Given this list of marker genes TNF, CREB1, DGKQ, GFI1, LMF1, STAR, LDLR, PAQR3, APOA1, ABCA2, GNB3 (NCBI Gene Id 2784), KIT, MIR27A, SNAI1, ERLIN2, H6PD, ERLIN1, FGFR4, ASAH1, NR1H4, ARV1, DKKL1, INSIG1, STAT5B, STUB1, TSPO, ARMC5, ABCB11, RORC, MIR33A, PANK2, MIR98, ATP1A1, SEC14L2, MIR96, GNAI1, TTC39B, KPNB1, MALRD1, AQP8 (NCBI Gene Id 343), ADM, BMP5, UGT1A1, ABCG1, SERPINA12, C7orf50, APOE, DGAT2, MBTPS2, IFNG, SREBF2, PRKACA, UGT1A8, RORA, NR5A2, CH25H, PRKG1, BGLAP, GPRC6A, NFKB1 (nuclear factor kappa B subunit 1), QKI, BMP2, CLCN2, FSHB, NR3C1, SREBF1, EPHX2 (NCBI Gene Id 2053), PDE8B, NR1D1, DKK3, CGA, ABCG4, GGCX, NR0B1, LPCAT3, SCP2, STARD4 (StAR related lipid transfer domain containing 4), STAT5A, WNT4, GAL, AGTR1, ACADVL, AKR1C3, GPR146, CYP7A1, SCAP, APOB, EGR1, BMP6, IGFBP7, DDX20, REST, PRKAA1, PROX1, NR5A1, CES1, DHH, MIR182 (NCBI Gene Id 406958), MBTPS1, MIR185, FGF1, INSIG2, FGF19, LDLRAP1, FMO5, SIRT1, LEP (NCBI Gene Id 3952), MIR342, MAPK1, MIR27B, ACADL, SNAI2, MIR548P, MIR30C1, DAB2 (NCBI Gene Id 1601), AGT, LHCGR, POR, here is a description of the gene set: Any process that modulates the frequency, rate or extent of the chemical reactions and pathways involving steroids. Human Gene Set: GOBP_REGULATION_OF_STEROID_METABOLIC_PROCESS species: Homo sapiens